Given this list of marker genes POLR2I, POLR2E, CTDP1, CDK9, NELFE, ELOB (elongin B), SUPT5H, ELOA, POLR2J, POLR2F, POLR2L, POLR2B, NELFA, POLR2H, SUPT16H, POLR2D, POLR2K, POLR2A (NCBI Gene Id 5430), GTF2F1, NELFB, TCEA1, tat, ELOA2, SSRP1, ELOC, CCNT1, NELFCD, SUPT4H1, POLR2G (RNA polymerase II subunit G), POLR2C, ELL, GTF2F2, here is a description of the gene set: Reactome Pathway: Tat-mediated HIV elongation arrest and recovery species: Homo sapiens part of: Transcription of the HIV genome RNA Pol II arrest is believed to be a result of irreversible backsliding of the enzyme by ~7-14 nucleotides. TFIIS reactivates arrested RNA Pol II by promoting the excision of nascent transcript ~7-14 nucleotides upstream of the 3' end.